The following is a description of a gene set: Mouse Gene Set: GOBP_ANGIOTENSIN_MATURATION species: Mus musculus The process leading to the attainment of the full functional capacity of angiotensin by conversion of angiotensinogen into mature angiotensin in the blood., and this is the list of marker genes: Anpep, Mme, Prcp, Prep, Cpa3, Ace2, Ren1, Ace, Atp6ap2, Enpep